Given this list of marker genes OLR1, KIF5C, PLA2G5, HORMAD2, NEK1, here is a description of the gene set: Genes predicted to be targets of miRBase v22 microRNA hsa-miR-5705 in miRDB v6.0 with MirTarget v4 prediction scores > 80 (high confidence targets). Human Gene Set: MIR5705 studied in species Homo sapiens from publication Chen Y, Wang X (PMID 31504780)